Given this list of marker genes SETD4, KMT5B, PRDM6, KMT5A, KMT5C, PRDM9 (NCBI Gene Id 56979), here is a description of the gene set: studied in species Homo sapiens Human Gene Set: GOMF_HISTONE_H4K20_MONOMETHYLTRANSFERASE_ACTIVITY Catalysis of the reaction: L-lysyl20- + S-adenosyl-L-methionine = H+ + N6-methyl-L-lysyl20- + S-adenosyl-L-homocysteine. This reaction is the addition of a methyl group to the unmethylated lysine residue at position 20 of histone H4, producing histone H4K20me.